Given this list of marker genes PAPPA2 (pappalysin 2), PVR, NHEJ1, ELAVL2, FOSL1, MSH3, EPHB2, FZD5, ABCB1, FLRT2, RXRG, CLCN3, COL8A1, SLC33A1, LGI1, NR3C2, DAZL, ARL3, GLE1, AQP7 (NCBI Gene Id 91114), PLPPR4, PHF10, ERC1, CYP2E1, ENOX2, ATP10B, CCN6, ZNF132, ATP4B, MAP2K7, CTRL, LPGAT1, ECM2, COX6A2, B4GALT6, GPR171, GPLD1, MPP3, SOAT2, LORICRIN, ZNF202, RORB, CPB2, PPP1R1A, CYP2D6, FNTB, CDC73, KDR, CAMK4 (calcium/calmodulin dependent protein kinase IV), HTR1E, PCM1, FGF2, PPP1R12B, CCL16, SGPL1, LDB3, SIX6, GMPR, ABO, TRIO, TMEM26, TPD52L1, HNF1A, F2RL1, KRT2, APOBEC1, CDH4, RBMS3, OR10H3, THPO, KLRC4, PART1, BIRC5, KCNA5, NTNG2, PRELID3A, ITGBL1, CRHR1, PHLDB1, BCL2L11, RBMXL1, COLGALT2, OTC, CFH, CCIN, CD8A, GUCY2F, MPZL1, ATP2B2, IL16, POU6F1, P2RY10, SPATA2, LILRA4, ULK2, DMPK (NCBI Gene Id 60405), PGM3, ABCC8, HSD3B2, MLLT10, IL11RA, PLEKHB1, PRPS1L1, PRKCA, ADAM20 (NCBI Gene Id 8748), TBX19, EDIL3, ITIH3, PCDHB17P, RGS7, TBXT, SLC15A1, ZNF266, RYR3, NOL4, TSSK2, SLC46A3, SULT4A1, ISL1, CYP11A1, CDC42BPA, IFNA10, ERCC4, ZBTB40, SURF2, HTR2C, F2RL3, ABCB10, DRD1, OCM, HCRTR2, PTPRB, TLL1, PAX9, IFNA14, AOC4P, MDM2, STXBP5L, CTSB, IL7, MON2, NPFF, HOXC11, SPRR2C, DNAJC16, CACNA2D1, IPO9, RREB1, RYR1, RUNX2, DNAJC22, CYP2C19, DMD, CALN1, GNG4, RB1CC1, MYH2, FAS, RPS6KA5, MAGI1, ERC2-IT1, WBP4, AMMECR1, PHOX2B, TNK1, PDE6A (NCBI Gene Id 5145), CMKLR2, TENM4, TFDP2, IFNA1 (NCBI Gene Id 89955), RAD51D, DRC3, PTPN20, GJB5, FGA, SLC4A8, NOS2, MINDY2, MSL3, COL14A1 (collagen type XIV alpha 1 chain), DBT, TANC2, PAXIP1, ADAMTSL3, CCR3, MAGEA8, PPP2R5B, LECT2, ATP8B1 (NCBI Gene Id 5205), BMP10, NPAS2, CDH8, ZSCAN26, ZBTB14, CDR1, UBE4B, BRD4, SYT5 (synaptotagmin 5), GPR18, IL4, SLC26A4 (NCBI Gene Id 5172), GLRA3, NEB, SCN7A, SIM2, PSG1, ZNF33B, ASB4, R3HCC1L, KNG1, RSC1A1, STAC, IGKV7-3, SLC22A6, ATXN3, HOXB7, ZNF157, MC5R, EXOC4, GCA, FGF18, POLR1HASP, GHRHR, ZNF141, THRA, FAM13A, TACC2, JADE3, FBXL4, SMYD3, SLC6A2, CADM4, SERPINA4, SLC17A1, ST8SIA1, NOVA1, SLC17A3, MYT1, SRPK3 (NCBI Gene Id 26576), PAX7, HEPH, LILRA1, COL19A1, NXPE3, CXCL5, ZNF134, SUPT3H, COQ7, NR1I2, GRIK1, AKAP3, MAGEA9, DGCR5 (DiGeorge syndrome critical region gene 5), TTTY1, PAX6, GUCY2C, PSD, PPM1E, CPEB3 (cytoplasmic polyadenylation element binding protein 3), SGCD, KLHL23, PDE4D, JRKL (NCBI Gene Id 8690), FUT1, IL5, TRIM24, LRP4, NEDD4L, BRCA1, PDCD1, MAP2, GPR19, IVL, KRT34, KRT86, OR2B6, ATF6B, H3C6, ATF2, NR2F1, USP46, KCNN3, CEP162, ROR2, GABRB2, SPA17, COL4A4, GCM1, FSHR, S100A5, here is a description of the gene set: Neighborhood of CAMK4 calcium/calmodulin-dependent protein kinase IV in the MORF expression compendium Human Gene Set: MORF_CAMK4 Neighborhood of CAMK4 species: Homo sapiens